The following is a description of a gene set: Human Gene Set: GTTTGTT_MIR495 species: Homo sapiens Genes having at least one occurence of the motif GTTTGTT in their 3' untranslated region. The motif represents putative target (that is, seed match) of human mature miRNA hsa-miR-495 (v7.1 miRBase)., and this is the list of marker genes: AFF2, ACTC1, ACVR1B, ANAPC1, HNRNPH1, EMSY, NFAT5, ZFX, PAQR9, THBS2, SLC35A2, HSDL2, MYT1L, RPRD1A, PCDHA13, STAG2, CDH13, JAG2, CBL, SOX5, RSBN1, MYLK, FBN2, GRM7, PDCD10, STRN, PCDHA7, HSPA5, ARMC8 (armadillo repeat containing 8), CPNE4, BDNF, SP1, HYCC2, BCL11A, ASB7, MVB12B, R3HDM2, CAMK2G (calcium/calmodulin dependent protein kinase II gamma), ZIC3, ZFAND3, RICTOR, HIPK1, BHLHE41, SOX6, REV1, HOXC6, PCDHA2, CD164, SPAST, PSME3, PER2, CDK6, TNRC6A, PRKY, JOSD1, MARCKS, BBOF1, DEDD, DYNC1LI2, AGBL5, RAI2, ARK2N, GMFB, CSTF3, NHLRC3, RBPMS2, ZFAND5, ST8SIA2, LHX2, RIMS4, EML4, TMED10, MAPK6, HOXC8, ATRN, SEL1L, FKBP5, SEPTIN7, CADM1, GSE1, DCLRE1B, NKRF, PCDHA8, PABIR2, TMED9, EPB41L4B, MBNL2, NR6A1, EPHB2, SGK1, CSNK1E, PELI1, CPEB3, FAM219A, BAIAP2, ST18, TMEM127, SRSF10, HNRNPH2, DYRK1A, WASHC4, DDX3X, CELF1, TMEM183A, PCDHA6, ELAVL1, PCDHA1, BUD13, LUC7L3, SNRPD1, RGS17, ZBTB18, SRSF5, BCL11B, CBFA2T2, RND3, DAG1, TNFRSF21, GPM6A, LRRK1, SGMS1, AP3M1, GLCCI1, ZNF503, IREB2, PDE4D, HBEGF, WDTC1, MGAT2, EPC2, NEUROD6, MTSS1, HMGXB4, YTHDC1, UBE2Q1, MINAR1, TIMP2, TRAPPC10, SEMA6D, DDX3Y, CNR1, DCAF6, ETS1, CELF2, DNAJC14, FAM133A, PPP3CA, YTHDF3, RLF, DDIT4, CRIM1, MARCHF7, SLF2, CDYL, SNRPB, MORF4L1, USP32, JUN, PPP6C, ANKRD13C, IGF1, NRBF2, SCN8A, PCDHA9, LARGE1, SSR1, PHF6, POU4F2, SP4, SRSF11, UBN1, RANBP1, PCDHA12, DUSP6, SLC38A2, PRKX, UBE2Z, SATB1, PRRT2, AP1G1 (adaptor related protein complex 1 subunit gamma 1), VPS13D, TGFB2, PCDHA4, DHX40, VCPIP1, ADAT2, PCDHA3, CAPZA1, VEZF1, MORF4L2, OGT, KLF13, NUFIP2, NHLH2, TARDBP, RUNX1T1, SUPT16H, TSC22D3, PLEKHH3, PCDHA5, EFCAB14, DMRT1, ACTR1A, PCDHAC1, ATP2B2, APPBP2, HOXB9, ILF3, MAML3, PAIP1, MLEC, MPPED2, CBX4, ARHGAP5, PLCH1, NAB2, S1PR3, USP32P2, RORB, NCOA1 (nuclear receptor coactivator 1), KCNJ2, ATP8A2, ABCA2, CREBZF, SKIDA1, ACACA, RASD2, MTCL2, CPSF6, HOMER1, VDAC2, MARK3, MOB3B, PCDHAC2, PRRC2A, PRR7 (proline rich 7, synaptic), HMGCLL1, KLF5, ZNF362, CYB5B, MDM1, FOXO3, RREB1, TWF1, NAA30, ADGRB3, PTCH1, PNN, PCDHA10, RUNX3 (RUNX family transcription factor 3), HNRNPU, PCDHA11, SOX9, TSHZ3, SCD, UBE3A, SSX2IP, SZRD1